The following is a description of a gene set: Human Gene Set: REACTOME_LONG_TERM_POTENTIATION studied in species Homo sapiens Long-term potentiation, and this is the list of marker genes: CAMK2G, GRIN1, CAMK2B, ACTN2, GRIN2A, DLG4, NRGN, GRIN2D, NEFL, CAMK2A, NRG1, ERBB4, DLG3, GRIN2B, LRRC7, CAMK2D, GRIN2C, DLG1, CALM1, DLG2, GRIA2, GRIA1, SRC